The following is a description of a gene set: species: Homo sapiens A process in which a protein is transported to, or maintained, in a location within a cell-cell junction. Human Gene Set: GOBP_PROTEIN_LOCALIZATION_TO_CELL_CELL_JUNCTION, and this is the list of marker genes: ACTB (actin beta), LSR, CDH5, FLNA, SCRIB, DSG3, ZDHHC7, DLG5, DSG2 (NCBI Gene Id 1829), F11R, TJP1, TJP2, CGNL1, HEPACAM, VCL, CTNND1 (catenin delta 1), ACTG1, JAK1, MAPK9, ABCB1, PECAM1, PAK2, DSP, TJP3, MPP7, ILDR1, ARHGEF18